The following is a description of a gene set: species: Mus musculus part of: Downregulation of ERBB2 signaling Reactome Pathway: Downregulation of ERBB2:ERBB3 signaling This event has been computationally inferred from an event that has been demonstrated in another species.<p>The inference is based on the homology mapping from PANTHER. Briefly, reactions for which all involved PhysicalEntities (in input, output and catalyst) have a mapped orthologue/paralogue (for complexes at least 75% of components must have a mapping) are inferred to the other species. electronically inferred by orthology from the curated human pathway, and this is the list of marker genes: Rps27a, Erbb2, Ubb